The following is a description of a gene set: studied in species Homo sapiens Opioid receptor pathways Human Gene Set: WP_OPIOID_RECEPTOR_PATHWAYS, and this is the list of marker genes: TUBB, ALDH9A1, CCK, CAP1, NOS2, PLEKHG1, PGM1, HMOX1, E2F1, HSPA8, NEU2, RAC1, HDAC1, TLR4, MAP1LC3B, HPCA, JUP, PIK3CG, ADCY1, RPLP2, RELA, GNA12, OPRL1, BDNF, GNAI2, OPRM1, ARC, CELF2, ADCY8, DNMT3A, RGS9, CACNA1B, SLC9A1, TNF, PRKCE, CACNB2, SQSTM1, GATA4, RGS4, PRKCG, MBP